The following is a description of a gene set: studied in species Mus musculus Mouse Gene Set: GOBP_CELLULAR_RESPONSE_TO_POTASSIUM_ION Any process that results in a change in state or activity of a cell (in terms of movement, secretion, enzyme production, gene expression, etc.) as a result of a potassium ion stimulus., and this is the list of marker genes: Dlg2, Nptx1, Mecp2, Abcc9 (NCBI Gene Id 58900), Dlg4, Nek7, Kcnj10, Stk39, Acta1, Crhbp, Slc12a2, Hnrnpa1, Mylk